The following is a description of a gene set: Genes predicted to be targets of miRBase v22 microRNA hsa-miR-1468-5p in miRDB v6.0 with MirTarget v4 prediction scores > 80 (high confidence targets). from publication Chen Y, Wang X (PMID 31504780) studied in species Homo sapiens Human Gene Set: MIR1468_5P, and this is the list of marker genes: CAMKMT, CD63, WTAP, NUB1 (NCBI Gene Id 51667), PROCA1, SERP1, COX8C, AASDH, UBXN10, SLC25A46 (solute carrier family 25 member 46), NCOA3, PSMG1, FUBP3, MEX3B